Given this list of marker genes RNH1, TMBIM6, DYNLL1, BRAT1, UBE3D, C1QBP, ABCE1, DFFA, here is a description of the gene set: Binds to and modulates the activity of a nuclease. Human Gene Set: GOMF_NUCLEASE_INHIBITOR_ACTIVITY species: Homo sapiens